Given this list of marker genes GOT1, APIP, GCAT, SMS, ADSS2, NAT8L, BHMT, PIPOX, MSRA, AADAT, ATF4, RIDA (reactive intermediate imine deaminase A homolog), PHGDH, MAT1A, ASNS, AASS, BHMT2, ASPG, MTHFR, GOT2, ASPA, ASRGL1, MTRR, DDO, NIT2, MTR, ADI1, PLOD3, PLOD2, GNMT, ENOPH1, ASNSD1, MTHFD1, GOT1L1, DLST, ASS1, SLC38A8, ADSS1, here is a description of the gene set: studied in species Homo sapiens Human Gene Set: GOBP_ASPARTATE_FAMILY_AMINO_ACID_METABOLIC_PROCESS The chemical reactions and pathways involving amino acids of the aspartate family, comprising asparagine, aspartate, lysine, methionine and threonine.